Given this list of marker genes DHCR7, SCARF2, IQCE, RPL10, SMOC1, DEAF1 (NCBI Gene Id 105376508, DEAF1 transcription factor), GABRA3, EBF3, CACNA1C, PRKD1, NECTIN4, MECP2, ATP9A, TP63, MCTP2, CAMTA1, BCOR, FGF16 (NCBI Gene Id 8823), SC5D, TRRAP, here is a description of the gene set: 2-3 toe cutaneous syndactyly species: Homo sapiens Human Gene Set: HP_2_3_TOE_CUTANEOUS_SYNDACTYLY